The following is a description of a gene set: The behavior in which an organism produces sounds by a mechanism involving its respiratory system. studied in species Homo sapiens Human Gene Set: GOBP_VOCALIZATION_BEHAVIOR, and this is the list of marker genes: BRINP1, EXT1, NLGN4Y, NLGN4X, GLI3, SRPX2, SLITRK1, MYH14, SHANK3, SHANK1, TIFAB, NRXN1, DLG4, DCANP1, NLGN3, CNTNAP2, NRXN3, FOXP2 (NCBI Gene Id 93986), NRXN2 (NCBI Gene Id 9379), SHANK2, NEUROG1